Given this list of marker genes Rpgr, Cdh1, Pramel29, Psmd3, Adra2a, Tspan17, Chmp7, Hipk2, Fbxw11, Trem2, Rhbdd1, Fbxl6, Sh3d19, Aup1, Agbl4, Klk4, Pabir1, Rad23a, Ntaq1, Cpb2, Mtor, Xbp1, Ptk2, Jkamp (NCBI Gene Id 70280), Chmp1b2, Wnt10b, Pramel22, Ubxn2b, Cdc34, Ern1, L3mbtl3, Spg11, Lnpep, Ppp1r11, Ubl7, Ift80, Armc8, Asb9, Csnk1d, Rilp, Septin3, Serpine2, Klhl29, Ambp (alpha 1 microglobulin/bikunin precursor), Hgsnat, Vps28, Phb1, Cts6, Edem1, Rnf4, Pramel27, Rnf25, Fbxo45, Mmp3, Pmaip1, Psmb9, Usp38, Trip4, Usp14, Pramel55, Axin1, Gusb (NCBI Gene Id 14929), E330034G19Rik, Pml, Sh3rf1, Itch, Usp44, Rps27a, Fbxo39, Klhl40, Vhl, Ddi1, Sco1, Derl1, Pramel20, Flna, Map3k1, Cul3, Ubqln2 (NCBI Gene Id 54609), Usp26, Lamp3, Otud5, Atg7 (NCBI Gene Id 74244), Ctnnb1, Paqr3, Wfs1, Bag2, Dnajb12, Lrp1, Crbn, Klhl28, Peli1, Pramel30, Spopfm2 (speckle-type BTB/POZ protein family member 2), Rybp, Chmp5, Dpp4, Erap1, Uhrf1, Mad2l2, Psme3ip1, Ndufa13, Tor1a, Pttg1ip, Usp7, Cblb, Marchf2, N4bp1, Kctd21, Csnk1e, Usp19, Wdr91, Man1b1, Pramel7, Canx, Trip12, Vps37b, Caml, Ins1, Ube2j2, Glb1, Klhl35, Adamts13, Rnf114, Psma8, Pramel47, Senp1, Fbxl17, P2rx7, Gsk3b, Mmp8, Sh3rf3 (SH3 domain containing ring finger 3), Fbxw7, Bag5, Traf2, Agap2, Rnf186, Shh, Faf1, Klhl20, Psmd10, Cenatac, Tmem259, Spata18, Mfsd8, Dysf, Pramel40, Hpse, Hspbp1, Dda1, Ttc36, Kctd13, Uchl4, Wwtr1, Bcas2, Mapk15, Clpp, Rcn3, Lipa, Plk2, Capns1, Cul9, Amfr, Fbxl12, Atp5if1, Faf2, Rnf26rt, Lyplal1, Nkd2, Tlk2, Neu4, Gna12, Man1c1, Cacul1, Pias1, Htra2, Cul4b, Ube2n, Chmp4b, Klhdc1, Ctso, Mmp12, Mta1, Sirt2, Vps37a, Ctsb, Apob, Apoc2, Birc2, Chmp3, Sirt6, Tnfrsf1b, Znrf2, Ube2r2, Chmp1a, Abhd12, Ubb (NCBI Gene Id 22187), Kctd5, Tbl1x, Pmp22, Akirin2, Nos2, Ccnf, Desi1, Ctsd, Trf, Rnf7l, Nop53, Hexb, Prmt6, Ankzf1, Ube2d3, Agap3, Cdc26, Mylip, Tmem199, Wdr26, Rnf146, Abca2, Midn, Oog2, Cdc16, Klhl7, Ube3b, Rchy1, Synpo2 (synaptopodin 2), Pisd, Cln8, Gzmn, Plg, Rnf34, Ube2h, Ppp2ca, Rhbdd3, Trim31, Tmem126a (NCBI Gene Id 66271), Marchf6, Mad2l1, Fbxl13, Fbxo10, Arel1, Fbxo48, Fbxo4 (F-box protein 4), Nkd1, Ceacam2, Mgat3, Fbxo7, Smurf2, Anapc2, Rbck1, Ophn1, Psmf1, Rnf8, Rnf144a, Ube2d1, Wdr77, Klhl41, Gabarapl2, Ascc3, Vgll4, Sumo1, Psmb8, Saysd1, Ubr2, Axin2, Fbxo31, Cul7, Sel1l, Atraid, Fem1al, Tnf, Grin2c, Afg3l2 (AFG3-like AAA ATPase 2), Pramel46, Hecw2, Pramel13, Cst3, Cdkn2a, Sumo3, Ankrd9, Gpld1, Cyp51, Azin2, Spopfm3, Znrf3, Trim3, Tdpoz9, Zfp598, Ccin, Cblc, Ric1, Ubxn7, Svip, Herc3, Calr3, Siah1a, Btrc (beta-transducin repeat containing protein), Kctd6, Araf, Ube2d2b, Oaz1 (ornithine decarboxylase antizyme 1), Cts3, Oog4, Uchl3, Aurka, Utp25, Liat1, Ubxn11, Rnf139, Gan, Arih2, Ube2d2a, Marchf7, Psma7, Klhl8, Rela, Vip, Ube2w (NCBI Gene Id 66799), Proca1, Mme, Fbxl22, Stt3b, Ubd, Kbtbd2, Pramel32, Anks1, Gba1, Asb11, Pramel21, Dcaf11, Rnf121, Sdf2l1, Klhl24, Cts7, Afg3l1, Serpinb1b, Ube3a, Sirt1, Adgrb1, Anapc5, Zp3r, Ubqln1 (NCBI Gene Id 97856), Ube2v2, Mycbp2, Rnf41, Hspa5, Grin2a, Klhl21, Trim9, Ube2z, Arsb, Abhd10, Appbp2, Afg2b, Lrig2, Tdpoz2, Rnf11, Rbx1, Snx1, Uba6, Odc1, Syvn1, Apc2, Psmb1, Fbxo44, Kbtbd3, Rnf115, Trim58, Fbxw5 (NCBI Gene Id 98864), Usp8, Socs4, Anapc11, Acr, Nfe2l2, Klhl11, Pramel24, Filip1l, Rmnd5b, Psmd13, Trpc4ap, Hspa1a (NCBI Gene Id 193740), Ddit3, Taf9, Nsf, Tgfb1i1, Cela2a, Snca, Serpinb1a, Fbxl20, Pramel14, Fem1c, Malt1, Samd9l, Fbxo27, Slc17a9, Nrros, Ubr5, Ubap1, Ubxn4, Nedd8, Sorl1, Hspa8, Ext1, Tcirg1, Fbxo6, Tmem132a, Yme1l1, Ppt1, Rspry1, Rnf19a, Klhl2, Nell1, Rnf13, Ube2s, Siah2, Psmb7, Anxa2, Pdcd6ip, Xpo1, Ascc2, Cdk5rap3, Ap5z1, Pramel17, Styx-ps, Otud7b (NCBI Gene Id 99649), Snhg15, Folh1 (NCBI Gene Id 53320), Psma2, Ndfip2, Tmf1, Abhd17a, Adamts7, Ubac2, Tbx21, Rbbp6, Pten, Dennd3, Apoe, Usp25, Mmp20, Fbxo11, Cd2ap, Fem1b, Ndfip1, Ivns1abp, Pin1rt1, Rdx, Sec61bl, Ctsj, Ube4b, Zfand2b, Kbtbd8, Hyal1, Trim40, Mcpt9, Rnf6, Manba, Prickle1, Gpr108, Plk3, Hdac6, Pramel51, Psma4, Klhdc3, Proc, Wac, Psmb6, Kbtbd12, Ogt, Hexa, Ctsc, Gga1, Pramel38, Det1, Csnk2b, Dact1, Ube2g1, Hace1, Crebrf, Commd1, Spop, Ubr1, Rad23b, Ubxn6 (NCBI Gene Id 76275), Dnajb9, Tdpoz5, Ercc8, Kctd10, Arih1, Eif2ak3, Rnf180 (ring finger protein 180), Spsb1, Rgma, Psap, Cdc23, Herc4, Galns, Mmp13, Gja1, Ctsk, Ide (NCBI Gene Id 73765), Ldc1, Sel1l2, Klhl18, Klhl5, Ctsq (cathepsin Q), Enc1, Nedd4l, Gzmc (NCBI Gene Id 14940), Ccar2, Rnf170, Edem3, Rnf148, Rnf126, Smurf1, Rnf123, Sh3rf2, Lypla1, Ube3c, Pdcl3, Socs7, Rack1, Calr, Ptpn3, Notch1 (notch 1), Btk, Kbtbd7, Rnft2, Asb1, Psmd8, Slc6a17, Fau, Rnf125, Rnf5, Rnf149, Trim72, Pramel31, Plk1, Timp4 (tissue inhibitor of metalloproteinase 4), Cops3, Lyset, Ids, Ppp2r3a, Lypla2, Pramel44, Sufu, Vps36, Klhl23, Cbl, Slc6a7, Psme2, Rpl23, Capn2, Skp1, Pramel1, Park7, Oog1, Ngly1, Rnf20 (NCBI Gene Id 97155), Arrdc4, Stam, Rnf217, Usp13, Ube2l3, Anapc7, Psma6, Stx5a, Dtx4, Bap1, Herpud1, Psma3, Gm13040, Calr4 (NCBI Gene Id 71031), Ecpas, Gid4, Rnf130, Sox17, Bmal1, Casp7, Notum, Gsk3a, Lpcat1, Pramel53, Cop1, Fem1a, Pramel36, Ubqlnl, Map1a, Psmc5, Fbxl9, Arrb1, Herc2, Adamts12, Fbxo17, Ctsl, Pramel33, Lrrc75a, Gclc, Usp9x, Ube2u, Anapc4, Trim71, Psmd2, Rpl5, Gabarap (gamma-aminobutyric acid receptor associated protein), Capn1, Pramel26, Ppp2r5c (protein phosphatase 2, regulatory subunit B', gamma), Zmpste24, Uchl1, Anapc10, Ubxn8, Wnt5a (wingless-type MMTV integration site family, member 5A), Smarcc1, Maea (macrophage erythroblast attacher), Pja2, Pgpep1, Psme1, Dnajc3, Siah3, Pramel37, Rnf122, Nccrp1, Stub1, Epg5, Ccdc115, Mmp14, Fbxl7, Vps37c, Rnf111, Ube2srt, Uba52, Psmc4, Ufsp2, Furin, Trim25, Fmn2, Rnf103, Dtl, Lonp1, Chmp6, Grn, Nhlrc3, Uchl5 (NCBI Gene Id 67598), Pramel48, Yod1 (YOD1 deubiquitinase), Pramel6 (NCBI Gene Id 97002), Ttc3, Oxa1l, Ubqln5, Kctd17, Pramel19, Clpx, Atxn3, Dedd, Tmx1, Ifng, Tmem9, Prkn, Klhdc10, Socs6, Zer1, Sharpin, Ldlr, Tpp1, Pdlim2, Erlin2, Ube2dnl1, Vcp, Pcbp2, St14, Chmp2b, Pramel28, Rnf10, Ceacam1, Rlim, Rnf167, Cma1, Nploc4, Rnf128, Zdhhc2, Neu2, Dnajc10, Gpc1, Nub1, Dcaf1, App, Ube2a, BC051665, Ube2k, Casp12 (NCBI Gene Id 12364), Psmd11, Rnf133, Nln, Irgq, Adam9, Cdc27, Gfap, 4930486L24Rik (RIKEN cDNA 4930486L24 gene), Zfand2a, Siah1b, Cd81, Aqp11, Ripk1, Alad, Ankrd11, Ctsr, Oma1, Sec22b, Trim26, Pramel45, Pramel41, Tspan5, Topors, Uba1y, Traf7, Psma5 (NCBI Gene Id 26442), Ltn1, Erlin1 (ER lipid raft associated 1), Dlgap1, Wdr81, Nemf, Klhl1, Prkcg, Tmem106b, Csnk2a2, Tsg101, Brinp1, Ubr4, Psma1, Rhobtb3, Traf4, Rnf145, Timp2, Pramel5, Trib1, Mmp2, Gns, Pkd1, Cdc20, Il1b, Spopl, Fbxl15, Dcaf12, Spsb3, Rnf150, Usp22, Ctsa, Pramel12, Lrsam1, Glmn, Casp8, Cav1, Pramel15, Kcmf1, Epha4, Hecw1, Gpc3, Edem2, Huwe1, Il10, Sgsh, Ins2, Wwp2, Fbxl2, Ate1, Mtm1, F8a, Efna1 (NCBI Gene Id 99598), Rnf43, Tiparp, Il17ra, Pramel35, Rnf168, Rnf7, Bnip3, Cdc20b, Capn3, Smad3, Rgp1, Rnf187, Ppp2cb (protein phosphatase 2 (formerly 2A), catalytic subunit, beta isoform), Nrg1, Atg5, Timp3, Trim39, Amn1, Ipp, Mapk8, Trim24, Dmac2, Vps35, Snx5, Nupr1, Fbxo2, Pbk, Slc6a8, Pramel23, Trim28, Ube2j1, Trim21, Psen2, Hectd3, Trib2, Dvl1, Trim45, Usp28, Fam83d, Anapc16, Vps4b, Il33, Snf8, Ptpn23, Keap1, Rpl11, Cpa1, Csnk2a1, Pacsin3, Psmb2, Fbxw8, Ecscr, Ctsh, Amer1, Dcaf13 (DDB1 and CUL4 associated factor 13), Oog3, Clu, Atp13a2, Nhlrc1, Ier3, Gzma, Styx, Trim32, Egln2, Fbxo22, Idua, Pithd1, Fyn, H13, Hfe, Laptm4b, Cul1, Socs2, Hsp90aa1, Foxf2, Fbxo38, Vps37d, Eloc, Rbx1-ps, Lrrk2, Fbxo3, Laptm5, Chmp2a, Tmem168, Asb5, Ufd1 (NCBI Gene Id 22230), Abhd13, Klhl25, Ctsf, Wwp1, Lamp2 (NCBI Gene Id 16784), Lonp2, Psmd1, Cts8, Uba1, Derl2, Arrdc1 (arrestin domain containing 1), Gga3, Cma2, Fbxl19, Psme4, Capn10, Nrdc, Fbxo24, Timp1, Gipc1, Psmd14, Klhl30, Vps11, Cul2, Azin1 (antizyme inhibitor 1), Mapk9, Rnf144b, Vps4a, Nedd4, Lats1, Wnt1, Psmb11, Prkaca, Phf20l1, Fbxo9, Fbxl5, Trim30a, Znrf4, Egfr, Adam10, Chfr, Bcap31, Ctsll3, Ube3d, Ark2n, Spsb4 (splA/ryanodine receptor domain and SOCS box containing 4), Brsk2, Gid8, Erlec1, Ube2b, Rmnd5a, Ube2c, Psmd6, Rnf215, Pja1, Bnip3l, Dpp3, Klhl4, Ankib1, Tmub2, Mkrn2, Sh3bgrl, Ubxn1, Tnfsf12, Os9, Cast, Nqo1, Mdm4, Anapc15, Ctsz, Tbl1xr1, Rffl, Man1a2, Klhl15, Clgn, Chmp1b, Tspan15, Rnf40, Fbxw4, Eif3h, Psmd4, Naglu, Kat5, Psmb3, Ubc (NCBI Gene Id 77003), Man1a, Rnft1, Mmp9, Cul5, Oaz2, Klhl17, Pcsk9, Rnf213, Foxo1, Mdm2, Zranb1, Cul4a, Klhl12, Ubr3, Dnaaf4, Sgsm3, Pabpn1l, Ccdc47, Kif14, Rab12, Lgmn, Tnfaip3, Bag6, Anapc1, Socs5, Cdkn1b, Ctsm, Osbpl7, Tdpoz4, Abhd17c, Dab2ip, Chek2, Ptk2b, Egf (NCBI Gene Id 99717), Pcyox1l, Cln3, Rgn, Irak3, Adam8, Ube2l6, Hyal4, Epm2a, Dab2, Tmtc3, Disc1, Hspa1b, Trim67, Cbfa2t3, Snx12, Nlrp1b, Pramel25, Rhbdf1, Fbxo43, Pramel11, Derl3, Rnf166, Pramel16, Sec61b, Psmb4, Prpf19, Tdpoz8, Fbxl18, Psmc3, Kcne2 (NCBI Gene Id 69143), Rab7, Cnot4 (CCR4-NOT transcription complex, subunit 4), Asb2, Mib1, Vps25, Plaa, Ccdc22, Nudt15, Trim63, Gm11690, Sqstm1, Akt1, Arrb2, Ubl4a, Atm, Hsp90ab1 (heat shock protein 90 alpha (cytosolic), class B member 1), Smad4, Ubap1l, Cdc34b, Snx9, Nfe2l1, Rnf216, Zfp418, Ddi2, Hmgcr, Dpp7, Snx33, Pramel18, Ark2c, Ambra1, Trim2, Tnfaip1, Cela1, Gpx1, Ube4a, Kctd2, Dcst1, Sox9, Ube2g2, Get4, Sgta, Sf3b3, Bnip3l-ps, Ubqln4, Uba7, Usp5, Tollip, Nr1d1, Trim38, Kbtbd6, Atg4b, Lonrf2, Ube2dnl2, Nsfl1c, Rnf185, Pramel43, Trib3, Zswim8, Apc, Tpp2, Fzr1, Psmc1, Klhl3, Ctrb1, Umod, Fbxl4, Rps7, Zyg11b, Tmub1, Hectd1, Snx3, Csnk1a1, Psmd7, Psmb5, Pin1, Klhl38, Ufl1, Klhl6, Pramel42, Gzmb, Psmc6, Pcyox1, Rnf14 (ring finger protein 14), Ubxn10, Fbxl16, Skp2, C4bp, Cpn1, Klhl22, Clock, Dtx3l, Klhdc2, Dnajb2, Psen1, Pramex1, Abhd17b, Herc6, Tmem67, Hsp90b1 (heat shock protein 90, beta (Grp94), member 1), Foxred2, Selenos, Rnf19b, Anapc15-ps (anaphase promoting complex C subunit 15, pseudogene), Hamp, Prep (NCBI Gene Id 28116), Ntan1, Ctss, Afg1l, Tmem129, Fmr1, Ctsw, Psmb10, Rc3h2, Isg15, Rc3h1, Bbs7, Qrich2, Fbxo8, Oaz3, Rybp-ps, Msn, Pcnp, Psmc2, Ezr, Vps13a, Fap, Pappa, Znrf1, Fbxl14, Casp3, Klhl42, Trim13, Tdpoz1, Chmp4c, Rnf26, Tdpoz3, Ddrgk1, Ecrg4, Anapc13, Lnx1, Fbxl3, Agtpbp1, Ubxn2a, Gm12610, Eif2a, Spsb2, Bfar, Klhl10, Ubqln3, Trp53inp2, Psme3, Otud7a, Fhit, Pramel60, Clec16a, Ddb1, Sumo2, here is a description of the gene set: Mouse Gene Set: GOBP_PROTEIN_CATABOLIC_PROCESS species: Mus musculus The chemical reactions and pathways resulting in the breakdown of a protein by the destruction of the native, active configuration, with or without the hydrolysis of peptide bonds.